Given this list of marker genes MAP2, PLPPR2, ACO2, IDS, LYNX1, DNAJC6, ANK2, MMD, GPD1, NNAT, ATP5F1B, MAP1A, RPH3A, MTCH1, KIFC1, GFM2, BSN, SULT4A1, NECAB2, HPCA, SNRPN, RAD51, SNURF, EEF1A1, SELENOW, NRGN, KIF5C, SLC17A7, RNF10, NSG2 (neuronal vesicle trafficking associated 2), CDK14, NETO1, EPS15, TMSB4X, MAP1B, CHGB, INA, here is a description of the gene set: from publication Lein ES, Hawrylycz MJ, Ao N, Ayres M, Bensinger A, Bernard A, Boe AF, Boguski MS, Brockway KS, Byrnes EJ, Chen L, Chen L, Chen TM, Chin MC, Chong J, Crook BE, Czaplinska A, Dang CN, Datta S, Dee NR, Desaki AL, Desta T, Diep E, Dolbeare TA, Donelan MJ, Dong HW, Dougherty JG, Duncan BJ, Ebbert AJ, Eichele G, Estin LK, Faber C, Facer BA, Fields R, Fischer SR, Fliss TP, Frensley C, Gates SN, Glattfelder KJ, Halverson KR, Hart MR, Hohmann JG, Howell MP, Jeung DP, Johnson RA, Karr PT, Kawal R, Kidney JM, Knapik RH, Kuan CL, Lake JH, Laramee AR, Larsen KD, Lau C, Lemon TA, Liang AJ, Liu Y, Luong LT, Michaels J, Morgan JJ, Morgan RJ, Mortrud MT, Mosqueda NF, Ng LL, Ng R, Orta GJ, Overly CC, Pak TH, Parry SE, Pathak SD, Pearson OC, Puchalski RB, Riley ZL, Rockett HR, Rowland SA, Royall JJ, Ruiz MJ, Sarno NR, Schaffnit K, Shapovalova NV, Sivisay T, Slaughterbeck CR, Smith SC, Smith KA, Smith BI, Sodt AJ, Stewart NN, Stumpf KR, Sunkin SM, Sutram M, Tam A, Teemer CD, Thaller C, Thompson CL, Varnam LR, Visel A, Whitlock RM, Wohnoutka PE, Wolkey CK, Wong VY, Wood M, Yaylaoglu MB, Young RC, Youngstrom BL, Yuan XF, Zhang B, Zwingman TA, Jones AR (PMID 17151600) Molecular approaches to understanding the functional circuitry of the nervous system promise new insights into the relationship between genes, brain and behaviour. The cellular diversity of the brain necessitates a cellular resolution approach towards understanding the functional genomics of the nervous system. We describe here an anatomically comprehensive digital atlas containing the expression patterns of approximately genes in the adult mouse brain. Data were generated using automated high-throughput procedures for in situ hybridization and data acquisition, and are publicly accessible online. Newly developed image-based informatics tools allow global genome-scale structural analysis and cross-correlation, as well as identification of regionally enriched genes. Unbiased fine-resolution analysis has identified highly specific cellular markers as well as extensive evidence of cellular heterogeneity not evident in classical neuroanatomical atlases. This highly standardized atlas provides an open, primary data resource for a wide variety of further studies concerning brain organization and function. species: Mus musculus Transcripts showing subcellular localization only to proximal dendrites in the adult mouse brain. Human Gene Set: LEIN_LOCALIZED_TO_PROXIMAL_DENDRITES